Given this list of marker genes Snap47, Myo5b, Scrib, Vps35, Rab8a, Grin2a, Arhgap44, Camk2a, Grip1, Lrrc7, Slc1a1, Epb41l1, Stx1b, Ap3d1, Rab11a, Stx3, Rab7, Mapk10, Neto1, Snap23, Zdhhc2, Grip2, Akap5, Snx27, Stx4a, Mylk, Clstn1, Sacm1l, Nsg1, Vamp2, Gripap1, Cplx1, here is a description of the gene set: The directed movement of neurotransmitter receptors. Mouse Gene Set: GOBP_NEUROTRANSMITTER_RECEPTOR_TRANSPORT species: Mus musculus